Given this list of marker genes PPP1R3C, GFPT1, AKT2, PFKM, PHKA2, GSK3A, WIPI2, GBE1, ENPP1, PPP1R3A, PHKA1, EPM2A, SELENOS, RUBCNL (NCBI Gene Id 80183), ACADM, PRLH, KHK, GAA, INS, PPP1R3D, PPP1R3G (protein phosphatase 1 regulatory subunit 3G), STBD1, HMGB1, GCK, GYS1, POMC, STK40, MRAP2, PID1, MT3, PPP1R1A, NHLRC1, PHKG2, PTH, EVA1A, MIR15B, INPP5K, PYGB, PPP1CC, MTOR, GCGR, ATG2B, PYGM, ADRB3, IL6ST, UGP2, GSK3B, GNMT, GYG2, PPP1R2B, IRS1, PPP1R2 (protein phosphatase 1 regulatory inhibitor subunit 2), ATG12, SELENON (NCBI Gene Id 7800), ATG3, IRS2, IGF2, KL, COMT, WDR45, COL6A1, PCDH12, PASK (PAS domain containing serine/threonine kinase), INSR, PGM2, G6PC1, PHKG1, GABARAPL1, PRKAG2, PPP1R2P1, WIPI1 (WD repeat domain, phosphoinositide interacting 1), PPP1R3B, SORBS1, RB1CC1, DYRK2, NR1D1, PPP1CB, IGF1, PPP1R3F, AKT1, GYS2 (glycogen synthase 2), GFPT2, EPM2AIP1, GRB10, LEPR, GYG1, PHKB (NCBI Gene Id 5257), ADGRF1 (adhesion G protein-coupled receptor F1), MIR1271, AGL, WDR45B, PPP1CA, PER2, PPP1R3E, ATG2A, ADGRF5, ADCY10, PRKAG3, LEP, MIR195, PHLDA2, PYGL, here is a description of the gene set: Human Gene Set: GOBP_ENERGY_RESERVE_METABOLIC_PROCESS The chemical reactions and pathways by which a cell derives energy from stored compounds such as fats or glycogen. species: Homo sapiens